The following is a description of a gene set: from publication Cui A, Huang T, Li S, Ma A, Pérez JL, Sander C, Keskin DB, Wu CJ, Fraenkel E, Hacohen N (PMID 38057668) studied in species Mus musculus Cytokines mediate cell-cell communication in the immune system and represent important therapeutic targets. A myriad of studies have highlighted their central role in immune function, yet we lack a global view of the cellular responses of each immune cell type to each cytokine. To address this gap, the authors created the Immune Dictionary, a compendium of single-cell transcriptomic profiles of more than 17 immune cell types in response to each of 86 cytokines (>1,400 cytokine-cell type combinations) in mouse lymph nodes in vivo. A cytokine-centric view of the dictionary revealed that most cytokines induce highly cell-type-specific responses. For example, the inflammatory cytokine interleukin-1β induces distinct gene programmes in almost every cell type. A cell-type-centric view of the dictionary identified more than 66 cytokine-driven cellular polarization states across immune cell types, including previously uncharacterized states such as an interleukin-18-induced polyfunctional natural killer cell state. Genes positively differentially expressed in cell type: cDC1 (conventional dendritic cell type 1) upon treatment with cytokine: IL-12 in mouse lymph nodes in vivo. Mouse Gene Set: CUI_CDC1_IL12_RESPONSE_UP, and this is the list of marker genes: Dusp5, Dtx3l, Parp14, Ly6e, Ptpn1 (NCBI Gene Id 19246), Tes, Iigp1, Ly6a, Slc33a1, Cmtm6, Phf11a, Trim30a, Plekhn1, Rcn2, Ilrun, Pfkp, Cct3, Kpna3, Irf1, Ctsz, Sdhc, Tuba1b, Srsf7, Basp1, Lap3, Lamp2, Cpne2, Ppa1, Nfu1, Ifi47, Tpm4, Stat3, Slfn2, Cxcl9, Pim1, Zyx, Ncbp3, Cd40 (CD40 antigen), Cst3, Sppl2a, Stat2, Igtp, G3bp1, Pkib, Nampt, Pml, Atp6v1g1, Tap1, Gnb4, Arpc4, Rars1, Ifi35 (interferon-induced protein 35), Irf8, Ube2l3, Acer3 (NCBI Gene Id 71401), Samhd1, Cxcl10, Lgals3bp, Serpina3g, Gbp9, Bbx, Vta1, Tnf, Slc4a8, Tspo, Pmepa1, Calhm6, Stat1, Uba7, Nlrc5, Pnp, Ccdc86, Arf6, Ms4a4c, Tle3, Aida, Slc30a4, Irgm1, Socs1